Given this list of marker genes SHMT2, LEMD3, BCOR, FANCD2, FANCE, FANCC, BMPR1B, RAB23, CHSY1, FANCA, ESCO2, GDF5, NAA10, here is a description of the gene set: Complete duplication of phalanx of hand Human Gene Set: HP_COMPLETE_DUPLICATION_OF_PHALANX_OF_HAND studied in species Homo sapiens A complete duplication affecting one or more of the phalanges of the hand. As opposed to a partial duplication were there is still a variable degree of fusion between the duplicated bones, a complete duplication leads to two separate bones appearing side to side (radio-ulnar axis) as seen on x-rays. A duplication leading to an accessory bone appearing in the proximo-distal axis on x-rays, is a different entity called a Pseudoepiphyses (see according terms) sometimes also referred to as Hyperphalangism.